The following is a description of a gene set: species: Homo sapiens Human Gene Set: GOMF_HISTONE_H3K36ME3_READER_ACTIVITY A histone reader that recognizes a histone H3 trimethylated at lysine 36., and this is the list of marker genes: MTF2, ZMYND11, PWWP2A, PHF1, MSH6, SGF29, PHF19